Given this list of marker genes LXN, MAP3K7, APLP2, H3-3B, RABGGTB, SCNM1, LPIN1 (lipin 1), BCAT2, GNAT2, FKBP5, ACSS1, NPTX1, MAPK8, SPRYD7, DTD1, C1QTNF12, RCC1, LPIN2, S100A11, IL1RL1, SOWAHA, PTPRCAP, SLC4A1, TLCD4, CMPK2, POLRMT, PPOX, ELOC, ALDH1A1, PKP2, CEP89, TCEA1, TAF1D, IFI16, GNA15, TUT7, SLC19A1, ARL4C, CUL2, DESI1, CREM, HCFC1, GFI1B, here is a description of the gene set: studied in species Mus musculus Human Gene Set: LIANG_HEMATOPOIESIS_STEM_CELL_NUMBER_LARGE_VS_TINY_DN We mapped quantitative trait loci that accounted for the variation in hematopoietic stem cell (HSC) numbers between young adult C57BL/6 (B6) and DBA/2 (D2) mice. In reciprocal chromosome 3 congenic mice, introgressed D2 alleles increased HSC numbers owing to enhanced proliferation and self-renewal and reduced apoptosis, whereas B6 alleles had the opposite effects. Using oligonucleotide arrays, real-time PCR and protein blots, we identified latexin (Lxn), a gene whose differential transcription and expression was associated with the allelic differences. Expression was inversely correlated with the number of HSCs; therefore, ectopic expression of Lxn using a retroviral vector decreased stem cell population size. We identified clusters of SNPs upstream of the Lxn transcriptional start site, at least two of which are associated with potential binding sites for transcription factors regulating stem cells. Thus, promoter polymorphisms between the B6 and D2 alleles may affect Lxn gene expression and consequently influence the population size of hematopoietic stem cells. from publication Liang Y, Jansen M, Aronow B, Geiger H, Van Zant G (PMID 17220891) Genes down-regulated in LSK cells (bone marrow) as a function of a QTL for the size of hematopoietic stem cell (HSC) population: comparison of congenic B.D. chr3 (BD, large HSC size) vs parental B6 strain (tiny HSC size).